Given this list of marker genes MPEG1, FCGR1A, IFI30, HLA-A, LNPEP, MFSD6, CLEC4A, FCER1G, IKBKB, here is a description of the gene set: studied in species Homo sapiens The process in which an antigen-presenting cell expresses a peptide antigen of exogenous origin on its cell surface in association with an MHC class I protein complex. The peptide antigen is typically, but not always, processed from a whole protein. Class I here refers to classical class I molecules. Human Gene Set: GOBP_ANTIGEN_PROCESSING_AND_PRESENTATION_OF_EXOGENOUS_PEPTIDE_ANTIGEN_VIA_MHC_CLASS_I